Given this list of marker genes DGKI, CD2, GNG13, ANXA5, KIF13B, IGHV3-30, H3C14, TUBB2A, PSG5, IGLV3-25, IGHV4-39, SIRPA, SH2B3, SOD1, KIF9, SELENOP, FCER1G, JAK2, IGKV1D-33, PRKCZ, ANXA2, GNB3 (G protein subunit beta 3), IFNA2, CYB5R1, KLC2, FGA, RBSN, KLKB1, SERPINC1, TRPC6, PSG8, KIF21A, PSG2, ITGA4, LY6G6F, EPCAM, OLR1, RASGRP1, ATP2B4, SYK, TUBB3, P2RX7, IFNA8, IRAG1, ECM1, ITGAM, PDGFA, APOA1, CD58, PPIL2, ORM2, DGKB, PDE1A, TIMP1, IGKV2D-28, ORAI2 (ORAI calcium release-activated calcium modulator 2), PIK3R2, RAB5A, HBE1 (NCBI Gene Id 3046), SERPINA3, HGF, A2M, IGHA1, IGKV1-17, CLEC3B (NCBI Gene Id 7123), AK3, SRC, MANF, IGLV3-27, VTI1B, ATP1B3, TF, S100A10, IGKV2D-30, STXBP3, GNAS, ITGA6, PFN1, EHD2, RHOA, GNG7, KIF22, SIN3A, TFPI, SLC8A3, FGB, GNB1, KIF26B, ATP1B2, BRPF3, TIMP3, CD47 (CD47 molecule), H3C3, KIFC1, RAC1, KCNMB4, ITGAL, FGG, IGLV2-14, NOS3, CEACAM6, GTPBP2, IGF2, ATP2B3, H3C1, KIF5B, P2RY1 (NCBI Gene Id 90963), GP9, MYB, TEK, DAGLB, PRKAR1B, PSG6, ANGPT4, KIFAP3, ABCC4, PROC, LHFPL2, CRK, RAC2, LRP8, DGKA, IGKV5-2, CABLES1, H3C6, IGHV3-13, CALU, KCNMA1, GATA5, IGLV2-11, ITGB2, ITPR2, H3C11, GNG12, MAFK (MAF bZIP transcription factor K), MAFF, VEGFD, SH2B2, AHSG, ATP2A3, PSG1, TUBB2B, IGHV1-2, CXADR, PSG4, IGHV2-70, HABP4, KCNMB2, IGLV1-44, RACGAP1, IGKV4-1, ATP2B1, MERTK, F7, DOK2, CAP1, SLC7A11, IFNA5, TNFRSF10A, GNG3, KIF27, ADRA2B, SLC3A2, KIF2B (NCBI Gene Id 84643), ATP2B2, PHF21A, ALDOA, MAFG, IGLV3-21, KIF1C, GYPC, RHOG, H3C13, PIK3CG, IGHV3-11, PDE11A, KIF20B, KIF21B, KIF4A, GATA4, SLC8A2 (NCBI Gene Id 6543), PLAT, APOH, PROS1, IGLC3, F12 (NCBI Gene Id 58992), IGHV3-53, A1BG, PAFAH2, KIF19, P2RX4, GATA6, GUCY1B1, CLU, IFNA10, KIF20A, LYN, RAP1B, TTN, RAP1A, PRKAR2A, FAM3C, TUBA3D, KLC4, APOOL (NCBI Gene Id 139322, apolipoprotein O like), IFNA17, PIK3R6, RCOR1, PLEK, TUBB8B, DGKZ, PPIA, PIK3CA, P2RX2, PHACTR2, SLC7A8, TUBB1, F11, IGHV1-46, H3-3B, RHOB, COL1A2, F2, IGKV1-5, TRPC3, RAPGEF4, CEACAM5, PTPN1, IGKV1-33, DOCK10, SERPINB6, JAML, IGLL1, RARRES2, ALB, NFE2, VEGFB, ITGA2, TBXA2R, KIF5A, ITGA10, GNG4, VPREB1, SLC16A3, ATP2A1, LGALS3BP, CEACAM3, CD244, VCL, MPIG6B, FGR (FGR proto-oncogene, Src family tyrosine kinase), ACTB, GRB2, PSG9, RASGRP2, IGHV3-23, PPP2R5A, DGKK, IGHV3-33, TUBA4A, VEGFC, TREM1, H3C4, SERPINB2, NHLRC2, DGKE, ZFPM2, TGFB3, TUBA8, GNG5, KLC1, KIF3B, PRKCB, TUBA1B, SERPINA1, IFNA6, P2RX3, CARMIL1, SPP2, STIM1, KIF6, VPS45, PPP2CA, SCG3, CAPZA1, RAPGEF3, SERPINE1, ITGB1 (integrin subunit beta 1), GNG2, KIF25, PIK3R5, CSK, PSAP (NCBI Gene Id 83009), RAB27B, DOCK2, TUBAL3, SLC7A9, APP, GP6, SLC7A5, KIF4B, AAMP, CAPZB, ITGA5, RAD51C, GNAT3, CENPE, H3C2, KIFC2, P2RX6, MGLL, F5, P2RX5, EGF, GRB14, IGHV2-5, MAPK14, IGHV4-34, DOCK4, SCCPDH, PDPK1, SRI, BCAR1, PLA2G4A, SLC7A10, TMSB4X, KIF15, HSPA5, APOB, HMG20B, TNFRSF10B, IFNA21, DOCK9, ITPR1, GNGT2, YES1, PPP2R5E, IGF1, HRAS, PSG7, PTK2, VAV2, SRGN, SERPINA5, F2RL3, IGHV1-69, TUBA1C, HRG, FCAMR, ITGA2B, ADAMTS13, KIF26A, MAGED2, CABLES2, H3C10, YWHAZ, THBD, L1CAM, SIRPG, CD84, PLAU, DOCK1, MMP1, PDGFB, PRKG2, ACTN1, JAM2, IGLV3-19, PPBP, MAPK1, IGKV1D-39, GNG11, SLC16A1, FN1, TMX3, SERPIND1, PSG3, PRKACG, F3, TUBB6, ARRB2, DGKQ, TNFRSF10D, PROCR, ITGAV, CDC42, IGKV1D-16, PF4V1, GP1BA, GNAQ, GNA14, DGKH, PDPN, IFNB1, SDC1 (syndecan 1), TAGLN2, TGFB2, OLA1, MFN1, P2RX1, PSG11, HDAC1, PRKACB, MPL, PRKAR2B, IFNA7, DOCK11, KNG1, CYRIB, ATP1B1, ITIH3, SERPINA4, ABHD6, CAPZA2, KRAS, PIK3R1, KIF3C, IGKV1-39, GP5, PCYOX1L, CD74, IGLV1-40, PDE9A, GNA12, IFNA16, KIF23, PRKCG, EHD3, IGHV3-7 (immunoglobulin heavy variable 3-7), MAPK3, PRCP, SERPINB8, AKAP1, CAV1, INPP5D, GNAI3, SELP, F13B, IFNA14, DGKD, ISLR, CEACAM1, NOS2, CFL1, ADRA2C, TSPAN7, KIF11, GNB4, GNA15, SLC8A1, KIF2A, SDC3, DOCK7, IGLC2, IGHA2, CD109, KIF3A, PLCG2, IRF2, MIF, ARRB1, IGLV7-43, PF4, F11R, ABL1, TUBA3E, GP1BB, H3C12, ITPR3, C1QBP, DAGLA, GPC1, ACTN4, IGKV1-12, APBB1IP, ABHD12, IGLV2-23, H3C15, THBS1, MFN2, CFD, JCHAIN, MMRN1, FLNA, CALM1, SELE, PPP2R1A, PPP2R5C, IFNA1, IGLV2-8, CDK2, GATA1, HBB, F9, PDE5A, CD99L2, KIF18B, ITPK1, PRKCA, DOCK6, RAF1, SERPINF2, IGLV1-47, SLC7A7, IGKV2-28, CTSW, KIF1B, STXBP2, GNA11, CD99, CD63, PPP2R1B, KLC3, PCDH7, SLC16A8, AKAP10, GNAI2, CD177, KCNMB3, GRB7, QSOX1 (quiescin sulfhydryl oxidase 1), APLP2, WEE1, PICK1, IGKV1-16, CD36, LCP2, HBG1, SLC7A6, PRKCQ, F8, IGHV3-48, JMJD1C, ANGPT2, GAS6, KIF2C, PDE2A, TOR4A, MICAL1, IGKV2-30, VEGFA, TP53, FYN, PTPN11, IGKV3-11 (immunoglobulin kappa variable 3-11), VAV3, GNA13, TLN1, GYPA, HBD, KIF18A, SELPLG, F10 (NCBI Gene Id 14058), VWF, IGKV3D-20, TUBB8, TUBA1A, PRKG1, ADRA2A, ITGB3, PPP2CB, TGFB1, GUCY1A1, CDK5, PPP2R5D, PLG, PLCG1, ITIH4, BSG, VPREB3, ORM1, LEFTY2, PRKCD, ESAM, PRKCH (protein kinase C eta), KIF1A, IFNA4, CLEC1B, GNGT1, TRPC7, IRF1, PDE1B, GYPB, ZFPM1, NRAS, ITGA3, GNB5, GATA3, STX4 (NCBI Gene Id 6810), H3C7, LCK, IGHM, ATP2A2, WDR1, IGKV3-15, GATA2, PIK3CB, PECAM1, MAG, DOCK5 (dedicator of cytokinesis 5), THPO, SDC2, CD48, IGHV4-59 (immunoglobulin heavy variable 4-59), CDC37L1, GNB2, SOS1, LAT, GNG10, HDAC2, GNG8, SHC1, KDM1A, SPARC, GNAI1, TUBA4B, COL1A1, ITGAX, DOCK3, TUBB4B, TEX264, PRKCE, CEACAM8, PRKACA, PTGIR, PRKAR1A, IFNA13, IGLV1-51, NOS1, IGKV1D-12, KIF12, ITGA1, SH2B1, AKT1, IGLV3-1, VAV1, H3C8, DOCK8, ACTN2, ENDOD1, SELL, GLG1, SYTL4, PPP2R5B, TUBA3C, LAMP2, F13A1, DGKG, F2R, CD9, FERMT3 (FERM domain containing kindlin 3), PLAUR, EHD1, PRTN3, SERPING1, KCNMB1, HBG2, PTPN6, SDC4, H3-3A, F2RL2, JAM3, KIF16B, PDE10A, RAD51B, IGKV3-20, IGLV6-57, PIK3R3, CD44, GUCY1A2, P2RY12, ORAI1 (ORAI calcium release-activated calcium modulator 1), IGKV2D-40, TUBB4A, CBX5, CHID1, ANGPT1, SPN, SERPINE2, here is a description of the gene set: species: Homo sapiens Human Gene Set: REACTOME_HEMOSTASIS Hemostasis